Given this list of marker genes RPL9, PDLIM2, FAAP100, RHOT2, EIF3E, PYGB, TSC22D4 (TSC22 domain family member 4), LRRC45, MAGEA3, STK11, RPS7, RPS17, MAST1, EEF1B2, NME3, NEUROG1, KRT18, PPP1R37, MCM7, PCSK1N, GPR78, SF3A2, BANP, TSSC4, DBP, NEUROG3, SLC22A8, ACP5 (NCBI Gene Id 54), DPP7, VPS28, UBXN1, CACNA2D3, EEF2, SPSB3, DUOXA2, BTF3, FBXL15, CORO1A, PRRC2B, RPL10 (ribosomal protein L10), PSTPIP1, CHAT, S100A5, RPSA, NKG7, RPS5, B4GALT3, APRT, OTUD7A, TNRC6C, SIPA1, LTB, JMJD8, TBCA, SLC13A5, TOP2B, DUSP15, CYTH4, PRPF6, VWA5B2, RPL22L1, TMC6, BPIFB2, SPEF1, GJC1, SRSF5, TCF3, PSMC5, LDHB, TCOF1 (NCBI Gene Id 6949), CHGA, ALDH16A1, MYO1G, UBA52 (NCBI Gene Id 7311), RPL6, RPS21, HADHA, TRABD, RPL5, SRSF1, IL24, RMND5A, GATD3, LTA4H, RPS2, SLC25A6, RPL39, EGLN2, NMRK2, RACK1, PLEC (plectin), SNAI3, GUK1, DENND4B, CTNNBIP1, RPL37A, VPS35, INPPL1, KLRB1, ZC3H11A, PNRC1, CHCHD5, TMEM259, RPS14, RPS3, MMS19, RPS4X, CTU1, RPS27A, RPL22, P4HB, POLM, CD244, RPS13, AMD1, DHX30, CXXC5, RABL6, RPL15, ACAA1, ARFGAP1, BCR, FAR2, CCNI, IGLV1-44, TSPAN4, RPS11, CHMP1A, DCBLD2, RPL13, ARL4C, BRAT1, CLPP, ARHGAP27, FBXW5, SGTA, PMEPA1, EEF1G, NCLN, NPEPL1, RPL3, RPS15A, EIF3F (eukaryotic translation initiation factor 3 subunit F), WDR18, COL6A2, GPR156, PREB, PRR15, FLNA, RPS3A, RDH13, EEF1D, EDARADD, ARL6IP4, CUTA (cutA divalent cation tolerance homolog), ITGA6, VAV1, RBM38, KIF22, PAF1, MRPL28, RPL35A, TMEM121, RPS15, SFI1, LIF, CCT7, RBM10, RPS10, PLIN1, QARS1, RPL11 (ribosomal protein L11), TCF25, GTPBP6, SESN2, ZBTB45, FKBP2, KDELR1, CHFR, NDUFB8, SNHG29, NDUFV1, C12orf57, TOMM7 (translocase of outer mitochondrial membrane 7), TNFAIP8, MAD2L2, MBD3, MN1, SGSH, ARHGAP4, AVP, IRGC (NCBI Gene Id 56269), AKR7A2, MTMR14, RGL2, CBX7, KIF1C, ACVRL1, RPL10A, RPL18A, LRP1, VPS51, ZAP70, HCLS1, CCM2, TUFM, ICAM3, RPL36 (NCBI Gene Id 92364), CD3D, FOXC1, CCDC88B, MAP7D1, SEC61A1, EIF4B, SNRNP200, ZNF423, HMGB1 (high mobility group box 1), RPL23A, OTOS, FHIP1B, RPL7A, TMEM63A, ADCY9, ATP5MJ, RPL18, CCT3, PPFIA4, RPS6 (ribosomal protein S6), CCT4, ARF5, SLC2A4RG (SLC2A4 regulator), INKA1, LCE1E, CYBC1, STX4, ENO1, ZNF681, MOB2, MEGF8, AKAP8L, PPP1R12C, PRB3, CLPTM1L, SLC4A1, EIF3L, here is a description of the gene set: Genes down-regulated in peripheral blood mononuclear cell (4 to 7)d vs 0d in adults (18-40) after exposure to YF-Vax, time point 4 to 7D from publication Scherer CA, Magness CL, Steiger KV, Poitinger ND, Caputo CM, Miner DG, Winokur PL, Klinzman D, McKee J, Pilar C, Ward PA, Gillham MH, Haulman NJ, Stapleton JT, Iadonato SP (PMID 17651872) Gene expression in human peripheral blood mononuclear cells was systematically evaluated following smallpox and yellow fever vaccination, and naturally occurring upper respiratory infection (URI). All three infections were characterized by the induction of many interferon stimulated genes, as well as enhanced expression of genes involved in proteolysis and antigen presentation. Vaccinia infection was also characterized by a distinct expression signature composed of up-regulation of monocyte response genes, with repression of genes expressed by B and T-cells. In contrast, the yellow fever host response was characterized by a suppression of ribosomal and translation factors, distinguishing this infection from vaccinia and URI. No significant URI-specific signature was observed, perhaps reflecting greater heterogeneity in the study population and etiological agents. Taken together, these data suggest that specific host gene expression signatures may be identified that distinguish one or a small number of virus agents. Human Gene Set: SCHERER_PBMC_YF_VAX_AGE_18_40YO_4_TO_7DY_DN studied in species Homo sapiens